Given this list of marker genes Tti2, Mak16, 7420700N18Rik, Snord13, Hmgb1-rs17, Wrn, Gm5117, Gm3985, Gm6853, Gm8168, Purg, Ubxn8, Rnf122, Gm8051, Gm22140, Gm38572, 4933433F19Rik, Tex15, Gm39154, Gm19096, Smim18, Gm6877, Gsr, 1700104B16Rik, Dusp26, Gtf2e2, Ppp2cb, Fut10, Nrg1 (neuregulin 1), here is a description of the gene set: studied in species Mus musculus Mouse Gene Set: chr8A3